Given this list of marker genes Cyp2c50 (cytochrome P450, family 2, subfamily c, polypeptide 50), Cyp2c55, Cyp26a1, Cyp3a41a, Cyp2w1, Cyp3a25, Cyp3a16, Cyp2c65, Cyp3a44, Cyp26b1, Cyp2c66, Cyp2c29 (NCBI Gene Id 13095), Cyp2c37, Cyp2c39, Cyp26c1, Cyp3a59, Cyp3a13, Cyp2c38, Cyp3a41b, Cyp3a11, here is a description of the gene set: species: Mus musculus Mouse Gene Set: GOMF_RETINOIC_ACID_4_HYDROXYLASE_ACTIVITY Catalysis of the conversion of retinoic acid to 4-hydroxy-retinoic acid.